Given this list of marker genes NUP93, CDKN2AIP, SHISA2, ZNF710, PLPBP (NCBI Gene Id 11212), RTN4RL1, TSTD2, DPYSL5, CDK13, SCAP (SREBF chaperone), KCNMB4, NFIC, EXPH5, ABCG4, SOX11, CACNB3, ZNF689, ADCYAP1, B3GAT3, DENND4C, UNG, UNC5A (unc-5 netrin receptor A), SAMD12, CCDC68, SRGAP2C, CX3CR1, MED13L, RAB43, ABCF1, MAP1LC3B, SESN3, RAP1GAP2, ULK2, ATP1A2, CNPY3, LUC7L3, TTC39C (tetratricopeptide repeat domain 39C, NCBI Gene Id 125488), MEF2A (myocyte enhancer factor 2A), ESYT2, USP3, TSHZ3, NEUROG1, KRTAP20-3, ZCCHC10, DSTN, MAP3K20, WTAP, STK35, NT5DC3, AIPL1, GJC1, TRAK2, APPL2, ADPRH, DAZAP2, MTDH (metadherin), ADCY1, XRN1 (5'-3' exoribonuclease 1), PDPR, ST6GALNAC6, ALDH8A1, CENPO, PSME1, ZSWIM6, DERA, BRD1 (NCBI Gene Id 29975), MAN1A1, PBX1, MED29, here is a description of the gene set: Genes predicted to be targets of miRBase v22 microRNA hsa-miR-1271-3p in miRDB v6.0 with MirTarget v4 prediction scores > 80 (high confidence targets). from publication Chen Y, Wang X (PMID 31504780) Human Gene Set: MIR1271_3P species: Homo sapiens